Given this list of marker genes GNA13, CSGALNACT2, PIM1, RBBP6, ZDHHC18, UGDH, ABHD3, PNPLA8, IER5, SIRT1, USP12, here is a description of the gene set: Genes from the lightyellow module which are up-regulated in HAEC cells (primary aortic endothelium) after exposure to the oxidized 1-palmitoyl-2-arachidonyl-sn-3-glycerophosphorylcholine (oxPAPC). species: Homo sapiens Human Gene Set: GARGALOVIC_RESPONSE_TO_OXIDIZED_PHOSPHOLIPIDS_LIGHTYELLOW_UP from publication Gargalovic PS, Imura M, Zhang B, Gharavi NM, Clark MJ, Pagnon J, Yang WP, He A, Truong A, Patel S, Nelson SF, Horvath S, Berliner JA, Kirchgessner TG, Lusis AJ (PMID 16912112) Oxidized phospholipids are thought to promote atherogenesis by stimulating endothelial cells (ECs) to produce inflammatory cytokines, such as IL-8. In studies with mouse models, we previously demonstrated that genetic variation in inflammatory responses of endothelial cells to oxidized lipids contributes importantly to atherosclerosis susceptibility. We now show that similar variations occur in cultured aortic ECs derived from multiple heart transplant donors. These variations were stably maintained between passages and, thus, reflect either genetic or epigenetic regulatory differences. Expression array analysis of aortic EC cultures derived from 12 individuals revealed that >genes were regulated by oxidized phospholipids. We have used the observed variations in the sampled population to construct a gene coexpression network comprised of 15 modules of highly connected genes. We show that several identified modules are significantly enriched in genes for known pathways and confirm a module enriched for unfolded protein response (UPR) genes using siRNA and the UPR inducer tunicamycin. On the basis of the constructed network, we predicted that a gene of unknown function (MGC4504) present in the UPR module is a target for UPR transcriptional activator ATF4. Our data also indicate that IL-8 is present in the UPR module and is regulated, in part, by the UPR. We validate these by using siRNA. In conclusion, we show that interindividual variability can be used to group genes into pathways and predict gene-gene regulatory relationships, thus identifying targets potentially involved in susceptibility to common diseases such as atherosclerosis.